The following is a description of a gene set: studied in species Homo sapiens Shock The state in which profound and widespread reduction of effective tissue perfusion leads first to reversible, and then if prolonged, to irreversible cellular injury. Human Gene Set: HP_SHOCK, and this is the list of marker genes: SDHA, MYL2, NAA10, PSMB9, SCNN1G, ABCC6, LMOD2, SCNN1A, ATRX, RPL3L, TRDN, DSP, JUP, SCNN1B